The following is a description of a gene set: Human Gene Set: REACTOME_ASSEMBLY_AND_CELL_SURFACE_PRESENTATION_OF_NMDA_RECEPTORS Assembly and cell surface presentation of NMDA receptors species: Homo sapiens, and this is the list of marker genes: NEFL, DLG3, DLG1, APBA1, GRIN2A (NCBI Gene Id 2903), TUBB4A, LIN7C, TUBB8B, DLG4, LIN7B, GRIN3B, GRIN2C, TUBB3, GRIN3A, CASK, KIF17, NBEA, CAMK2B, TUBA1B, GRIN1, TUBAL3, TUBA3E, TUBB2A, TUBB6, TUBB4B, TUBA8, TUBA3C, DLG2, CAMK2A, TUBA3D, TUBA1A, GRIN2D, TUBB1, LRRC7 (leucine rich repeat containing 7), TUBB8, CAMK2G, CAMK2D, TUBA4B, GRIN2B, TUBA1C, TUBB2B, ACTN2, TUBA4A, LIN7A